The following is a description of a gene set: Genes down-regulated during primary acute viral infection in CD8A dendritic cells: wildtype versus IFNAR1 knockout. studied in species Homo sapiens Murine Cytomegalovirus (MCMV) infection leads to early activation of various immune cells, including B and T lymphocytes, before the actual initiation of antigen-specific adaptive immunity. This activation is partly driven by innate cytokines, including type I interferon (IFN), which are induced early after infection. The objective of this study was to address the role of type I IFN in shaping early/innate B and T cell responses to a primary acute viral infection. In order to decipher the specific impact of IFN-I on cell subsets, we performed a genome-wide expression analysis on WT splenic B and CD8 T lymphocytes isolated from C57BL/6 mixed bone marrow chimera mice. This study complements series GSE39555, which focused on early responses of NK cells and of the two subsets of conventional dendritic cells. Human Gene Set: GSE45365_WT_VS_IFNAR_KO_CD8A_DC_MCMV_INFECTION_DN, and this is the list of marker genes: COL9A1, FMO5, KCNA2, ST6GALNAC2, XCL1, HAUS2, AKR1C4, PTP4A3, FLNC, SLC5A4, CKAP2, CCHCR1, CD1D, ACAD10, OR10J1, MSLN, CD320, C10orf95-AS1, IL2RA, PPP1R2C, BID, MEPCE (methylphosphate capping enzyme), ANKRD55, TAF1, URB1, RAMP1, APBA2, RDH16, PLLP, MYL3, FCN1, TRIOBP, TEAD4, TNXB, ACTL7A, HEATR6, CAV3, ADAP1 (ArfGAP with dual PH domains 1), CDKL1, SCGN, GNB3, SDHAP1, MMP24, ADAMTS12, FMOD, ATXN8OS, CPA4, NIPAL3, H4C2, TTPA, SLC27A2, LINC01949, HAP1, SEMA3G (NCBI Gene Id 56920), IGLJ3, CLEC11A, ETV3, SLC2A11, TTI2, CELA2B, MORC4, CAV2, GJB5, SLC12A5, CDK5R1, PRKAR2A, SULT4A1, RPL37A, MTNR1A, H4C7, ATP10B, PTGES, VPS50, DSG1, SLC10A2, KLF2, DOC2B, TAF5L, C11orf16, TFCP2L1, VNN2, LINC00939, ERCC1, WIPI2, PDLIM4, GABRA2, GLS2, MTCP1, SERGEF, CD3G, USP29, GAD2, NPDC1, GTF2H3, CNNM4, MYL4, RBMS3, NFIB, HLA-K, DGCR6L, ALAD, XPNPEP2, ASXL2, TRPM8, VSTM4, TEF, LCE2B, BRINP1, KRT85, PCDHGA8, OR51E2 (olfactory receptor family 51 subfamily E member 2), GCNT3, ZBTB7A, ATP1B4, SLC19A4P, FAAH, NOSIP, SMAD9, HOXB5, OTC, KDM4A, GREB1, POU5F1B, KRT33B, VHL (NCBI Gene Id 8056), MTMR12 (myotubularin related protein 12), B3GNT4, EPN3, MTTP, UPK2, GRIK3, DCAF16, VPREB1, FST, LARP6, PLD1, DUSP13B, RORC, ADGRA2 (adhesion G protein-coupled receptor A2), LIN7B, CTSF, GABRE, ADRA1B, KRT18, POM121L2, PTPRM, PLCH1, SND1, BNC2, PTPRH, HSPB8, TNP2, PSMD4, COQ7, ADORA1, DNASE2 (NCBI Gene Id 1777), SEC61B, WNT2, ETS1, CPE, OR7C1, MC1R, MYBPC2, DGKG, MARK1, HNF1A (NCBI Gene Id 6927), WDR83OS, VEZT, CAND2, C6orf62, CWH43, WT1, DUSP4, CR1, SERTAD3, GDAP1L1, LIN28A, NCALD, ITGA8, CXCR6, PRDX2, DBH, PRORP, KCNJ5, ALOX12P2 (arachidonate 12-lipoxygenase pseudogene 2), SMTN, LEF1, BEST2, GPATCH8, ANKEF1, TSSK2, TGFB2, KIR2DL3